Given this list of marker genes HECTD1, STAT4, AFDN, ARL4C, ALDH3A1, CNN3, PPP2R2C, ST6GALNAC2, ASCC1, STK17B, REXO2, NLRP2, CS, SLC26A2, RABGGTA, RPP30, PGAM1, YWHAQ, GJB2, ACAA1 (NCBI Gene Id 30), MALL, SLC16A6, GOLGA2, DUSP7, SHMT1, FOSL2, ALDH4A1, NCOA1, RAB6A, RAC1, KIF1C, GPX3, TSPAN5, MAL, GFOD2, PHF1, CR2, NCOA3, SLC1A3, TRIM13 (tripartite motif containing 13), SLC27A4 (solute carrier family 27 member 4), OXCT1, PMM1 (phosphomannomutase 1), TXNDC17, CRYAB (NCBI Gene Id 1410), CDK7, ATXN3, AP3S1, TRIM37, C5orf22, STIM1, S100A11, ARF3, DUSP5, IMPA1 (NCBI Gene Id 3612), MAPKAPK3, DDX3X, AMFR, TIAM1, ACOX1, PGF, CAPNS1, PPP4R1, EREG, NRP1, PLXNC1, TBC1D10A, NHERF1, GM2A, FPGT, NUCB2, ENDOD1, GTF3C1, NSDHL, SH3GL1, ZER1, FUT1, S100A12, PITPNA, NRBP1, PRDX6, UPP1 (NCBI Gene Id 7378), EPHX1, HCAR3, DNAJB1, STK38, SEPTIN8, TSPAN6, CAST, MOSPD3, GPC1, KCNK5, ALDH1A3, RXRA, ADIRF, ADIPOR1, KRT5, ADK, PDCD4, IGFBP2, WWP1, here is a description of the gene set: from publication Wang S, Zhan M, Yin J, Abraham JM, Mori Y, Sato F, Xu Y, Olaru A, Berki AT, Li H, Schulmann K, Kan T, Hamilton JP, Paun B, Yu MM, Jin Z, Cheng Y, Ito T, Mantzur C, Greenwald BD, Meltzer SJ (PMID 16449976) Down-regulated genes specific to esophageal adenocarcinoma (EAC) relative to normal tissue. species: Homo sapiens Human Gene Set: WANG_ESOPHAGUS_CANCER_VS_NORMAL_DN To investigate the relationship between Barrett's esophagus (BE) and esophageal adenocarcinoma (EAC), we determined gene expression profiles of discrete pathological stages of esophageal neoplasia using a sequence-verified human cDNA microarray. Fifty one RNAs, comprising 24 normal esophagi (NE), 18 BEs, and nine EACs were hybridized to cDNA microarrays. Five statistical analyses were used for the data analysis. Genes showing significantly different expression levels among the three sample groups were identified. Genes were grouped into functional categories based on the Gene Ontology Consortium. Surprisingly, the expression pattern of BE was significantly more similar to EAC than to NE, notwithstanding the known histopathologic differences between BE and EAC. The pattern of NE was clearly distinct from that of EAC. Thirty-six genes were the most differentially modulated, according to these microarray data, in BE-associated neoplastic progression. Twelve genes were significantly differentially expressed in cancer-associated BE's plus EAC (as a single combined tissue group) vs noncancer-associated BE's. These genes represent potential biomarkers to diagnose EAC at its early stages. Our results demonstrate that molecular events at the transcriptional level in BE are remarkably similar to BE's-associated adenocarcinoma of the esophagus. This finding alarmingly implies that BE is biologically closer to cancer than to normal esophagus, and that the cancer risk of BE is perhaps higher than we had imagined. These findings suggest that changes modulated at the molecular biologic level supervene earlier than histologic changes, and that BE is an early intermediate stage in the process of EAC.